The following is a description of a gene set: from publication Amit I, Citri A, Shay T, Lu Y, Katz M, Zhang F, Tarcic G, Siwak D, Lahad J, Jacob-Hirsch J, Amariglio N, Vaisman N, Segal E, Rechavi G, Alon U, Mills GB, Domany E, Yarden Y (PMID 17322878) species: Homo sapiens Genes whose expression peaked at 60 min after stimulation of HeLa cells with EGF. Signaling pathways invoke interplays between forward signaling and feedback to drive robust cellular response. In this study, we address the dynamics of growth factor signaling through profiling of protein phosphorylation and gene expression, demonstrating the presence of a kinetically defined cluster of delayed early genes that function to attenuate the early events of growth factor signaling. Using epidermal growth factor receptor signaling as the major model system and concentrating on regulation of transcription and mRNA stability, we demonstrate that a number of genes within the delayed early gene cluster function as feedback regulators of immediate early genes. Consistent with their role in negative regulation of cell signaling, genes within this cluster are downregulated in diverse tumor types, in correlation with clinical outcome. More generally, our study proposes a mechanistic description of the cellular response to growth factors by defining architectural motifs that underlie the function of signaling networks. Human Gene Set: AMIT_EGF_RESPONSE_60_HELA, and this is the list of marker genes: VEGFA, CCN1, GPRC5A, SNAI2, EXOC5 (NCBI Gene Id 29024), DNAJC24, KLF10, RUNX3, FOSL2, PMAIP1, PLSCR1, RHOB, LDLR, NKTR, PER1, BHLHE40, NR4A2, SLC2A3, CCND1, MOAP1, TIPARP, NR4A3, PTPN11, LIF, HES1, MBNL2, SLC20A1, DCUN1D4, NAA15, CITED2, UGCG, TRIM52-AS1 (NCBI Gene Id 101928649), SERPINE1, HSPH1, SOD2, FOXC1, ZFP36L1, KCNJ12, MED20, FOSB, NCKAP1, ATG4A (autophagy related 4A cysteine peptidase), CCN2, TNFAIP2, PKM, KLF6, FXR1 (FMR1 autosomal homolog 1)